The following is a description of a gene set: Human Gene Set: GSE2770_TGFB_AND_IL4_VS_TGFB_AND_IL12_TREATED_ACT_CD4_TCELL_2H_DN Th1 and Th2 cells arise from a common precursor cell in response to triggering through the TCR and cytokine receptors for IL-12 or IL-4. This leads to activation of complex signaling pathways, which are not known in detail. Disturbances in the balance between type 1 and type 2 responses can lead to certain immune-mediated diseases. Thus, it is important to understand how Th1 and Th2 cells are generated. To clarify the mechanisms as to how IL-12 and IL-4 induce Th1 and Th2 differentiation and how TGF-beta can inhibit this process, we have used oligonucleotide arrays to examine the early polarization of Th1 and Th2 cells in the presence and absence of TGF-beta after 0, 2, 6 and 48 hours of polarization. from publication Lund R, Aittokallio T, Nevalainen O, Lahesmaa R (PMID 14607935) Genes down-regulated in CD4 T cells activated by anti-CD3 and anti-CD28: TGFB1 and IL4 (2h) versus TGFB1 and IL-12 (2h). species: Homo sapiens, and this is the list of marker genes: POLG, SEPHS1, ATAD1, HMGN5, AKIRIN2, NHEJ1, CRLS1, WWP2, H2BC12L, NUBP1, NFKBIA, MLEC, GPR107, POLR3B, SELENOS, ITPKC, CLIC4, H1-10, RNGTT, SLC25A33, ABITRAM, DHX35, LARP1B, PEX7, SGF29, COG7, TMEM128, NT5DC2, DNAJC10, PPP3CC, SNRPA1, PSMD13, DUSP4, PLAUR, TFB2M, SETD4, ATP6V0A2, H3C2, ARPC3, CXorf38 (chromosome X open reading frame 38), METAP1, NUP54, MRPL42, ARL1, RAD21, WDR45B, TRIP11, ARL16, DCP1A, FTH1, YWHAH (tyrosine 3-monooxygenase/tryptophan 5-monooxygenase activation protein eta), UBE3A, CUL4A, C1QBP, RNASE11, SFT2D2, TXNDC12, ANGPTL8, GLRA1, TNFRSF9, PLXNA1, METAP1D, TERF1, H4C9, PBDC1, BLOC1S4, PCP4L1, MTMR2, FBXW4P1, FTH1P5, H1-2, COPS7A, ENOPH1, SSR3, SLC38A6, ZBTB6, SLC3A2, MRPL19, PDE4DIP, LIN7C, PFDN4, UBR3, FCN1, NAA50, TTC27, AK2, HUS1, ANKHD1, GPAT4 (NCBI Gene Id 574440), QTRT2, SLC25A32, MRPS28, GABRE, PDE4D (NCBI Gene Id 654081), FTSJ1, ASF1A, LIG3, MTFMT, ALKBH8, PPIP5K1, VDAC1, PHAX, JMJD6, POMGNT1, NEURL4, PPP2R1B, CD58, PTPN7, NUS1P3, SUCLA2, CPNE5, SFPQ, CXCR3, DOT1L, TRIM27, DDX47, TAF1A, MFSD14B, RABL3, SFXN4, EMG1, DPY19L1, ARL13B, DAG1, SLC1A5, PRMT6 (protein arginine methyltransferase 6), SYNPR, DBH-AS1, LANCL2, PPIB, SEC24A, MED6, ARMC10, GRPEL2, BZW1, OPA1, ZCCHC9, TYW3, LTC4S, SYNCRIP, ATP6V0E1, PPIF, TACC1, H2BC12, FUT2, GABRD, CCP110, EOGT (NCBI Gene Id 79580), EIF4G2, COX7B, UNK, EFHD2, AFDN, NDUFC1, P4HB, CNNM1, HCAR1, CAPZA1, PIGA, ERICH1, CYP20A1, NSUN2, UBE3C, SEC61G, DNAAF5 (dynein axonemal assembly factor 5), LSM6, ZNF579, ZNF329, TOMM40L (NCBI Gene Id 84134), NAT10, TOMM22, TRUB1, CDC37, TVP23B, IPPK, INIP, LRP12, CA5A, CUTC, TMOD3, ABCF2, BNIP1, LYRM4, ZFAND5, POGLUT1, GTF2H2, RPP40, EIF3B, PAFAH1B2, WSB2, LYPD1, PER2, WBP4, RBM12, CHP2